The following is a description of a gene set: Human Gene Set: HP_DECREASED_METHYLMALONYL_COA_MUTASE_ACTIVITY Decreased methylmalonyl-CoA mutase activity species: Homo sapiens An abnormality of Krebs cycle metabolism that is characterized by a decreased rate of methylmalonyl-CoA mutase activity., and this is the list of marker genes: MMAA, MMACHC, MMAB, MMADHC, PRDX1 (NCBI Gene Id 5052)